The following is a description of a gene set: An abnormality in the dynamic mode, rate, or form of thought processes as recognized from the flow of ideas expressed in speech. Successive thoughts and speech are easily diverted by external stimuli or internal superficial associations. Unable to maintain a constant train of thought and loose themselves in side issues, losing the thread and are unable to recover it. Superficial connections appear to drive the subject matter. Disordered formal thought process Human Gene Set: HP_DISORDERED_FORMAL_THOUGHT_PROCESS studied in species Homo sapiens, and this is the list of marker genes: POLG, ADA2, TREX1, NONO, HERC2, GRN, HNRNPC, SPTBN1 (NCBI Gene Id 91654), TWNK, TMEM106B, EMC10, DYM, TACO1, VCP, PRNP, CIC, USP7, VPS13A, NPC2, TBL1X, SQSTM1, ERF, TARDBP, CHMP2B, HTT, TREM2, DMPK, CHCHD10, TMEM163, FUS, CLTC, SLC2A3, TBK1, PSEN1, TTPA, NOTCH3, MAPT